Given this list of marker genes BROX, RCC1, VPS4A, REEP4, SIRT2, ANKLE2, BANF1, UBE2I, REEP3, SPAST (NCBI Gene Id 6683), here is a description of the gene set: A mitotic cell cycle process which results in the assembly, arrangement, or disassembly of the nuclear inner or outer membrane during mitosis. Human Gene Set: GOBP_MITOTIC_NUCLEAR_MEMBRANE_ORGANIZATION studied in species Homo sapiens